The following is a description of a gene set: studied in species Homo sapiens Human Gene Set: GOBP_RIG_I_SIGNALING_PATHWAY The series of molecular signals initiated by the binding ssRNA or dsRNA from another organism to the cytoplasmic pattern recognition receptor (PRR) RIG-1 (also known as DDX58). RIG-I detects RNA synthesized during viral replication or shed by non-viral pathogens, and triggers a signaling pathway to protect the host against infection, for example by inducing the expression of cytokines., and this is the list of marker genes: PUM1, RNF135, OAS3, CLPB, ANKRD17 (NCBI Gene Id 84177), ZCCHC3, SEC14L1, PHB2, ZC3HAV1, USP17L2, RNF125, BIRC3, PHB1, LSM14A, PUM2, OASL, DHX58, BIRC2, C1QBP, USP15, HDAC6, GPATCH3, DDX60, TRIM15, RIGI, NLRX1, NPLOC4, TRIM25, NOP53, UFD1